Given this list of marker genes Tut7, Piwil4, Tut4, Tdrd12, Mov10, Morc2a, Dnmt3a, Dnmt3l, Tasor, Smyd5, Dnmt3b, Tdrd5, Spin1, Mphosph8, L1td1, Ubr2, Trex1, Apobec3, Gm38999, Mov10l1, Pgbd5, Tdrd9, Tdrd1, Morc1, Fkbp6, Tex19.1, Tex19.2, Mael, Zfp869, Piwil1, Piwil2, Tex15, Spocd1 (SPOC domain containing 1), Sirt6, Sirt7, Resf1, Setdb1, Ddx4, Asz1, Btbd18, here is a description of the gene set: Mouse Gene Set: GOBP_TRANSPOSITION studied in species Mus musculus Any process involved in mediating the movement of discrete segments of DNA between nonhomologous sites. For elements that are transcribed as the first step of transposition, the process starts with the transcription of the transposable element, its translation and maturation, and ending with integration into DNA. For elements that are cut out, the process starts with the excision of the donor DNA and integrated into another site.